The following is a description of a gene set: species: Homo sapiens part of: Diseases of DNA Double-Strand Break Repair Reactome Pathway: Defective homologous recombination repair (HRR) due to BRCA1 loss of function In addition to its role in DNA double-strand break (DSB) signaling, BRCA1 plays an important role in homologous recombination repair (HRR) of DSBs by directly promoting recruitment of PALB2 and indirectly BRCA2 to DSB repair sites. In addition, BRCA1 increases the speed and processivity of DNA end resection which consists of 5′–3′ nucleolytic degradation of DSBs. The direct BRCA1 interaction with PALB2 helps to fine-tune the localization of BRCA2 and RAD51 at DSBs. PALB2 simultaneously interacts with RAD51, BRCA2 and RAD51AP1. PALB2 and RAD51AP1 synergistically stimulate RAD51 recombinase activity, thus enhancing RAD51-mediated strand exchange (branch migration) and promoting the formation of D-loop structures (synaptic complex assembly). A D-loop structure is formed when complementary duplex DNA (sister chromatid arm) is progressively invaded by the RAD51 nucleoprotein filament, with base pairing of the invading ssDNA and the complementary sister chromatid DNA strand.<br><br>The N-terminal region of BRCA1 contains the RING domain (residues 7-98), required for the heterodimerization of BRCA1 with BARD1. BRCA1:BARD1 heterodimer has E3 ubiquitin ligase activity which is important for DNA repair. Several missense mutations within the RING domain have been linked to increased risks of developing breast/ovarian cancers. BRCA1 mutant proteins impaired in BARD1 binding are annotated in the pathway "Defective DNA double strand break response due to BRCA1 loss of function".<br><br>The C-terminal region of BRCA1 which contains two coiled coil domains (residues 1397-1424) and two BRCT domains (residues 1642-1736 for BRCT 1; residues 1756-1855 for BRCT 2) is involved in PALB2 binding, with the second coiled coil domain being essential. Several cancer-associated BRCA1 missense mutants that affect the C-terminal region were shown to have reduced ability to bind PALB2. In addition, many nonsense and frameshift mutations in BRCA1 reported in cancer result in truncated proteins that lack the PALB2-binding domain., and this is the list of marker genes: BARD1, RMI1, ATM, SEM1, RAD51B, NBN, RAD51C, RAD51D, BLM, PALB2, RMI2 (RecQ mediated genome instability 2), DNA2, BRIP1, XRCC2, RBBP8, RAD51, RAD51AP1, BRCA1, TOP3A, KAT5, MRE11, EXO1, RAD50 (RAD50 double strand break repair protein), WRN, BRCA2